Given this list of marker genes SLCO2A1, CYP4B1, CYP3A5, CYP2D6 (NCBI Gene Id 1569), GSTK1, ACKR3, CYP2C8, CYP3A4, ABCC2, VDR (NCBI Gene Id 7421), CYP4F2, CYP2B6, GSTO1, GSTT1, here is a description of the gene set: Toxic compounds such as carcinogens are removed from the body by the action of a series of detoxifying enzymes and transporters expressed in the liver and the small intestine. We have found that intestinal epithelial cells expressing the SV40 large T antigen (TAg) contain significantly lower levels of mRNAs, encoding several drug metabolizing/detoxifying enzymes and transporters compared to their non-transgenic littermates. In addition, TAg blocks the induction of these mRNAs by xenobiotics. The repression depends on an intact LXCXE motif in TAg, suggesting that inactivation of the retinoblastoma (Rb) family of tumor suppressors plays a role in the process. These results imply that a functional Rb pathway in the intestine is necessary for the expression of the detoxification system used to clear carcinogens, and suggest that loss of this tumor suppressor might alter susceptibility to chemical injury. In addition, the effect of TAg on the detoxification pathway appears to be tissue-specific, as its ectopic expression in the liver failed to suppress the P450 enzymes. The TAg-mediated suppression of drug metabolizing/detoxifying enzymes may have broad implications in the metabolism and mechanism of action of both carcinogens and prescription drugs. from publication Sáenz-Robles MT, Toma D, Cantalupo P, Zhou J, Gong H, Edwards C, Pipas JM, Xie W (PMID 17334401) Detoxification pathway genes down-regulated in enterocytes of transgenic mice expressing SV40 T antigen. species: Mus musculus Human Gene Set: SAENZ_DETOX_PATHWAY_AND_CARCINOGENESIS_DN